Given this list of marker genes HNRNPD (NCBI Gene Id 548), CAMKK2, HNRNPR, MTREX, KHSRP (KH-type splicing regulatory protein, NCBI Gene Id 8570), PPP1CC, DIAPH1, GTF2A2, GNB1, MDC1, MYCBP2, PRPF40A, TREX2, LRPPRC, ASXL1, SLC35E2A, TNPO3 (NCBI Gene Id 404679), ESD, RAD23A, NDUFS4, SDHB, XPO7, TOMM70, POM121, KRIT1 (KRIT1 ankyrin repeat containing), RBPJ, USP24, VDAC3, EIF4EBP2, YARS1, CDC16, CBR4, MPHOSPH9, MAPRE1, ARIH2, BAZ1B, DKC1, IMMT, NPM3, VDAC2, EIF1AX, HCFC1, TARDBP, PTDSS1, DDX19B, XRCC5, PDIA6, IARS1, ERCC5, NSUN5P2, ANAPC5 (NCBI Gene Id 51433), RMND5A, RNF44, SRRM1, PRKDC, TM9SF2, DDX19A, SMARCC1, PIBF1, ZFC3H1, KXD1, UPF3A, CBFB, DUT, AK2, SRP72, SAFB, PDXDC2P-NPIPB14P, DEAF1, NSD2, DCTD, MBNL1, ANP32A, SLBP, DDX39B, here is a description of the gene set: Human Gene Set: MORF_CDC16 studied in species Homo sapiens Neighborhood of CDC16 CDC16 cell division cycle 16 homolog (S. cerevisiae) in the MORF expression compendium Neighborhood of CDC16